Given this list of marker genes FURIN, PCSK6, NGF, PCSK5, here is a description of the gene set: part of: Expression and Processing of Neurotrophins All neurotrophins (NTs) are generated as pre-pro-neurotrophin precursors. The signal peptide is cleaved off as NT is associated with the endoplasmic reticulum (ER). The resulting pro-NT can form a homodimer spontaneously which then transits to the Golgi apparatus and then onto the trans-Golgi network (TGN). Resident protein convertases (PCs) can cleave off the pro-sequence and mature NT is is targeted to constitutively released vesicles. The pro-NT form can also be released to the extracellular region. studied in species Homo sapiens Reactome Pathway: NGF processing